The following is a description of a gene set: Mouse Gene Set: ZHANG_UTERUS_C4_MYOFIBROBLAST Table S2: Representative genes of each cell cluster studied in species Mus musculus from publication Zhang L, Long W, Xu W, Chen X, Zhao X, Wu B (PMID 35669188), and this is the list of marker genes: Fosb, Matn2, Ufc1 (NCBI Gene Id 66155), Rpl15, Gm5835, Dpt, Tmem45a, Rps6-ps4 (NCBI Gene Id 672620), Sfrp4, Loxl2, Igfbp6, S100a10, 2310022B05Rik, Rpl18-ps2, Nr4a2, Srm, Tmem167, Myc, Klf4, Ptgis, Atf5, Col15a1, Gm8355, Cd248, Yipf5, Socs3, Gadd45g, Etfa, Vkorc1, Ppp1r2, Pmp22 (peripheral myelin protein 22), Eif4ebp1, Rpl22l1, Dcbld2, Gm3788, Ccn1, Rassf8, Ddit4l, Rpn2, Col6a3, Socs1, Umps, St3gal5, Rn18s-rs5, Gm10123, Anxa6, Ssr2, Hmgn2, Rps7-ps3, Nrp1, Bhlhe40, Nenf, Nr4a1, Tlnrd1, Gm10250, Gja1, Selenos, Tcf21, Adamts4, Nop58 (NCBI Gene Id 55989), Gm5586, C1ra, Rpl31-ps8, Ecm1, Ccl2, 1700086L19Rik, Serf2, Ost4, Prss23, Maged2, Rpl10a-ps1, Bzw2, Ezr, Jak1, Arl6ip5, Dnajb4, Pcolce, Tgfbr2, Rbm3, Uqcc2, Hdac1, Ddost, Pnrc1, Loxl1, Dbi, Vcan, Ehd2, Gm15772, Rps27rt, Raly, Fermt2, Vapa, Btg1, Gm5526, Ccl7, Rpl37rt, Plat (NCBI Gene Id 51950), Rps18-ps3, Gpx7, Limd1, Gm6204, Igf1 (insulin-like growth factor 1), Wdr89, Ssr3, Pnp, Clec3b, Tax1bp1, Il6st (NCBI Gene Id 71317), Emp1, Lamb1, P4ha1, Pdia3, Rcn3, Trib1, Ly6a, Rps27a-ps3, Gm9385, Rhoc, Rps10-ps2, Wsb1, Adh1, Sgk1, Carhsp1, Gas6, Copb2, Fbn1, Anxa1, Ifrd1, Hdlbp, Oaf, Egr1, Mmp19, Rps15a-ps7 (ribosomal protein S15A, pseudogene 7), Rab1a, Fkbp9, Cavin3, Cxcl1, Tubb2a, Rps26-ps1, Adamts2, Hmox1, Eif4e, Col16a1, Ccnl1 (cyclin L1), Hk2, Rps19-ps6, Pofut2, Fstl1, Cd63-ps, Pttg1ip, Selenom (selenoprotein M), Myadm, Mxra8, Sqstm1, Rasd1, Tspo, S100a6, Adm (adrenomedullin), Copz2, Flnc, Rps25-ps1, Hspb8, Gm8797, Tpm4, Rpl14-ps1, Sec24d, Col4a1, Anxa3, Frmd6, Tnfrsf12a, Cnot8, Vim, Rpl3-ps1 (NCBI Gene Id 674874), Fn1, Gm12481, Mt2, Dnajb1, Serpinh1, Cnn3, Ctsk, Rcn1, Csrp2, Tnfsf9, Nppc, Gng12, Gm5805, Prnp, Serpinb6a, Icam1, Fgl2, Sphk1, Ubb, Ppic, Stt3a, Serpinf1, Rpl18-ps1, Gem, Pgr, Sec61g, Hpgd, Sec13, Col14a1, Rps3a2, Gm10073, Nfkbia, Arl1, Plod2, Col5a3, Rps18-ps5, Rpl35, Myl6, Mesd, Ampd3, Erh, Kdelr2, Lgals1, Slc16a2 (NCBI Gene Id 278071), Gfpt2, Cryab, Col6a1, Pdpn, Gm11478, Btg2, Fos, Gapdh, Mmp23, Gm14303, Gm10132, Ifi204, Col6a2, Spon2, Aamp, Rpl38-ps2 (NCBI Gene Id 674951), Gstp1, Rpn1, Col1a1, Rps23-ps1, Ly6c1, Gpx8, Gm10177, Erp44, Maff, Rpl35rt, Gstp-ps, Swi5, Prdx4, Gm13588, Cxcl16, Vcam1, Gm13436, Slc25a4, Col6a4, Hspa5, Crtap, Tgfb2, Ackr3, Maged1, Rps6, Mt1, Col5a2, Ubb-ps, Atp5mg, Gm7536, Rbbp7, Ubc, Csf1, Eef1g, Gm5905, Ap2m1, Ppib, Copg1, Anxa2, B4galt5, Grcc10, Smim7, Gm8730, Txndc5, Tnfaip6, Arf4, Rps13-ps2, Tspan3, Copb1, Tpt1-ps3, Rpl39-ps, Cd44, Thbs1, Ugdh, Ltbp4, Gm4366, Col3a1, Meg3, Gstm5, S100a11, Sec22b, Gm6136, Pi15, Ppp1r15a, Cd302, Ift20, Zfp36l1, Gnas, Fkbp7, Hsph1, Pdia6, Efemp1, Errfi1 (NCBI Gene Id 74155), Ptpn5, Nab2, Nucb1, Spon1, 9530068E07Rik, Tgoln1, Tpm1, Gna13, Col1a2, Lmna, Sar1a, Klf6, Sgce (sarcoglycan, epsilon), P4ha2, Oxtr, Csrnp1, Ugp2, Trabd2b, Cdkn1a, Gm14586 (predicted gene 14586), Itgb1, Acaa2, Fkbp10, Tiparp, Cxcl10, Serpine1, Sap18, Gm10076, Mapre1, Ckap4, Mdm2, Gm6863, Itga5, Hmgn1, Sparc, Socs2, Ssr4, Rps15a-ps6, Rnf19a, Gm10275, Plpp3, Tubb6, Eef1a1, Msrb2, P4hb, Lum, Has1, Ist1, Rpsa-ps10, Col5a1, Calu, Ifi205, S100a16, Eif1a, Nfkb1, Gm15421, Oat, Gm15427, Atf3, Tpm2, C1qtnf6, Gm12338, Olfml3, Surf4, Gsn, Akr1c14, Morf4l2, Rpl10-ps3, Rpl9-ps6, Tuba1a, Dcn, C3, Gm10736, Rpl28-ps1, Flrt2, Cd55, Pim1, Snhg18, Ptprs, Rpl19-ps11, Slc25a39, Postn, Inhbb, Oaz1-ps, Ran, Adamts1, Lox, S100a1 (S100 calcium binding protein A1), Ogn, Plk2, Foxo1, Uba52, Ftl1-ps1, Ngfr, Nme2, Tmed3, Vegfd, Azin1, Cd34, Il4ra, Tceal8, Gstm2, Uap1, Cttn (cortactin), Sdc4